The following is a description of a gene set: Any process that modulates the frequency, rate or extent of relaxation of muscle. Mouse Gene Set: GOBP_REGULATION_OF_RELAXATION_OF_MUSCLE studied in species Mus musculus, and this is the list of marker genes: Abcc8, Camk2d, Nppc, Actn3, Pde4d, Hrc, Pawr, Sln, Grk2, Tifab, Sri, Akap6, Ttn, Chga, Neurog1, Pln, Camk2g